Given this list of marker genes MAPK8, JUN, FOS (Fos proto-oncogene, AP-1 transcription factor subunit), MAPK10, MAPK9, here is a description of the gene set: Pathway Definition from KEGG: (Vpr,Tat) -> JNK -> AP1 Human Gene Set: KEGG_MEDICUS_PATHOGEN_HIV_VPR_TAT_TO_TNF_JNK_SIGNALING_PATHWAY species: Homo sapiens HIV Vpr/Tat to TNF-JNK signaling pathway. Pathway ID: N00447. Pathway type: Pathogen. Pathway class: nt06516 TNF signaling.